The following is a description of a gene set: from publication Travaglini KJ, Nabhan AN, Penland L, Sinha R, Gillich A, Sit RV, Chang S, Conley SD, Mori Y, Seita J, Berry GJ, Shrager JB, Metzger RJ, Kuo CS, Neff N, Weissman IL, Quake SR, Krasnow MA (PMID 33208946) studied in species Homo sapiens Human Gene Set: TRAVAGLINI_LUNG_LYMPHATIC_CELL, and this is the list of marker genes: STMN1, CST3, HOXD8, LAPTM5, TSPAN5, LAMC1, FHL3, RAB3IL1, SCRN1, NHSL1, SMAD1, RAB11FIP5, TIMP2, TSHZ2, TFF3, SFRP1, PLBD1, HSPB1, RADIL, MGLL, IGFBP5, BCAT1, PRKCQ-AS1, WFS1, FAM107B, SLC24A1 (solute carrier family 24 member 1), TBX1, SLC43A3, BACE2, DSP, FABP5, NNMT, GGT5, RARRES2, GPR182, MEDAG, C6orf141, CCL21, CREB5, MMRN1, COL6A2, PDE2A, CHST12, EMILIN1, LOX, GYPC (glycophorin C (Gerbich blood group)), CHST15, FSCN1, OST4, PDLIM4, HEBP1, ELK3, MMP2, MFAP4, GSTA4, LSP1, SIRPA, LIMS1, FILIP1, APOLD1, PKHD1L1, EFEMP1, MAP7D3, C1orf198, SPHK1, RPL29, CTSD, FHL2, KRT18, PROX1, AKAP12, RPS2, ADGRG3, CRTAC1, APOD, DTX1, NTS, ANXA2, ADD3 (adducin 3), LGALS3, NR2F1, ELN, P4HA3, ABHD17B, GLT8D2, NTN1, SEMA3A, SLC7A1, CHRDL1, DIPK2B, MAF, SMYD2, RAB11FIP1, SGCE, SCN3B, HS3ST1, RELN, GGTA1, HYCC1, PIEZO2, SLCO2B1, NRP2, SCNN1B, CLU (NCBI Gene Id 1191), B3GNT7, FAM162B, PGM5, PLP2, PTX3, LYVE1, LY96, LTBP4, SLC38A1, LYN (LYN proto-oncogene, Src family tyrosine kinase), RTKN, FLNC, DHODH, GAS7, MEGF6, PDGFA, PHLDB2, PTPN3, CCDC80, CD200, LMNA, GPM6A, OAF, TXN, PPFIBP1, ABHD2, SLC35E4, FN1, UTRN, LAYN, PDE1A, MRC1, RPL39, AIG1, GNAS, MGST1, EEIG1, FABP4, MAP1B, PRR5, PGAP4, STON2, LRATD1, HOXD9 (homeobox D9), FAM174B, ACKR2, RHOJ, ACTN1, SLC38A2, PPP1R2, MIR4435-2HG, RGS16, PALM (paralemmin), BATF3, COLEC12, SNCG, TMEM98 (NCBI Gene Id 26022), PTPRE, NR2F2, IGFBP7, EFNA5, MPP7, PLIN5, SMOC1, IGF1, LRRN4CL, RASGRP3, ANGPT2, TM4SF18, NFIA-AS2, TRIP6, DKK3, PDGFC (platelet derived growth factor C), FLT4, P3H2, CD47, IRF8, GLIPR2, PARD6G, ARL4A, FRMD6, TNFAIP8L3, KLHL4, MFAP2, TGFBI, S100A10, STAB2, ARID5B, CFH, UCP2, HOMER3, ADD3-AS1, SCN9A, BCL7C, PRKAA2, DMTN, RPL7, SEMA3D, CXXC5, DAD1, NR2F1-AS1, LIF, PDPN, LAMA4 (NCBI Gene Id 3910), UBTD1